Given this list of marker genes Mthfr, Mmut, Comt, Mtr, Dpep1, Cps1, Mthfd1, Mpst, Cbs, Cth, Nox4, Mtrr, Blmh, here is a description of the gene set: Mouse Gene Set: GOBP_HOMOCYSTEINE_METABOLIC_PROCESS The chemical reactions and pathways involving homocysteine, the amino acid alpha-amino-gamma-mercaptobutanoic acid. Homocysteine is an important intermediate in the metabolic reactions of its S-methyl derivative, methionine. studied in species Mus musculus